Given this list of marker genes HTR1B, RGS2, CASR, ADORA1, SOD1 (superoxide dismutase 1), BDKRB2, ITGA1, ADCY6, SCNN1B, GCLC, TBXAS1, AVP, EXT1, GAB1, PIK3C2A, GUCY1A1, SLC6A4, PECAM1, ACE2, GRIP2, NPR1, AVPR1A, VEGFA, ITGA9, MANF, S100A1, ADD3, ITGB1BP1, ADRB1, ACE, ADM, FAAH, UCN (urocortin), VSTM4 (NCBI Gene Id 196740), MAS1, EDN3, NOS3, ABCC9, AVPR2, CD38, TNF, MIR138-1, ROCK1, RHOA, ASIC2, RAP1GDS1, DOCK5, ITGA4, MIR153-1, HTR2B, LEP, KNG1, ATG5, P2RX1, CRP, ROCK2, BBS2, INS, EXT2, SLC8A1, HTR2A, ENSG00000274276, EDNRB, EDNRA, ADORA2B, ABL1, KLF2, WNT9B, ADRA1D, MMP2, PLOD3, STUB1, EDN2, ITGB1, KCNMA1, TRPM4, GJA5, MIR92A1, ATP1A2, CALCA, ADRB3, KEL, FGA, ECE1, F2RL1, ZDHHC21, KCNJ8, APLN, AGTR1 (NCBI Gene Id 9449), SMTNL1, SCARB1, KCNMB4, HTR1D, F2R, TBXA2R (NCBI Gene Id 6915), FOXC1, ADRA2A, KAT2B, DOCK4, UTS2R, FGG, OXTR, NPPC, FGB, NPPB, UTS2B, P2RY2, NOS1, KCNA5, DRD1, CPS1, PRKG1 (NCBI Gene Id 5592), ACTA2, MRGPRD, GPER1, AGT, BMPR2 (NCBI Gene Id 659), CAV1, ADRA1B, ADORA2A, SOD2, HBB, NPPA, DBH, CBS, GPX1, ARHGAP42, SERPINF2, KCNMB2, ADRA2B, EDN1, SVEP1 (sushi, von Willebrand factor type A, EGF and pentraxin domain containing 1), GCLM, FOXC2, AGTR2, HRH1 (histamine receptor H1), PPARD, PER2, MIR21, APOE, PTPN11, AVPR1B, ADRA1A (adrenoceptor alpha 1A), SCPEP1, NTS, ATP2B1, MAP2K1, MTNR1B, SRC, UTS2, DRD5, P2RY1, MKKS, HRH2, TACR1, ADRB2, HTR1A, ADRA2C, IRAG1, COMP, HTR7, BLOC1S6, here is a description of the gene set: species: Homo sapiens Human Gene Set: GOBP_REGULATION_OF_TUBE_SIZE Ensuring that a tube is of the correct length and diameter. Tube size must be maintained not only during tube formation, but also throughout development and in some physiological processes.